Given this list of marker genes Egfr, Hif1a, Gpnmb, here is a description of the gene set: Reactome Pathway: PTK6 promotes HIF1A stabilization electronically inferred by orthology from the curated human pathway studied in species Mus musculus part of: Signaling by PTK6 This event has been computationally inferred from an event that has been demonstrated in another species.<p>The inference is based on the homology mapping from PANTHER. Briefly, reactions for which all involved PhysicalEntities (in input, output and catalyst) have a mapped orthologue/paralogue (for complexes at least 75% of components must have a mapping) are inferred to the other species.